Given this list of marker genes PIK3R1, IGF2, YWHAH (NCBI Gene Id 7533), SOCS2, INSR, YWHAG, IRS1, SOCS1, SHC1, ARRB1 (NCBI Gene Id 408), INSL4, REN, CRK, INS, IGF1, GNAS, here is a description of the gene set: studied in species Homo sapiens Human Gene Set: GOMF_INSULIN_LIKE_GROWTH_FACTOR_RECEPTOR_BINDING Binding to an insulin-like growth factor receptor.